The following is a description of a gene set: studied in species Mus musculus Mouse Gene Set: GOCC_NUCLEAR_EXOSOME_RNASE_COMPLEX A ribonuclease complex that has 3-prime to 5-prime processive and distributive hydrolytic exoribonuclease activity and endoribonuclease activity, producing 5-prime-phosphomonoesters. Participates in a multitude of cellular RNA processing and degradation events preventing nuclear export and/or translation of aberrant RNAs. Restricted to processing linear and circular single-stranded RNAs (ssRNA) only. RNAs with complex secondary structures may have to be unwound or pre-processed by co-factors prior to entering the complex, esp if the 3-prime end is structured., and this is the list of marker genes: Exosc4 (NCBI Gene Id 76326), Wdr74, Exosc6, Mtrex, Nvl, Exosc2, Exosc5, Dis3, Exosc3, Exosc8, Exosc9, Exosc1, Exosc7, Exosc10, Mphosph6